Given this list of marker genes GPRC6A, WNT4, DKKL1, INHBA, PRKG1, HSD17B3, SRD5A2, GGCX, CREB1, AKR1C3 (aldo-keto reductase family 1 member C3), CYP19A1, BGLAP, HSD17B1, here is a description of the gene set: The chemical reactions and pathways resulting in the formation of testosterone, an androgen having 17beta-hydroxy and 3-oxo groups, together with unsaturation at C-4 C-5. Human Gene Set: GOBP_TESTOSTERONE_BIOSYNTHETIC_PROCESS studied in species Homo sapiens